Given this list of marker genes Colec10, Fcnb, C1qc, C1ra, Fcna, Igll1, Gzmm, Colec11, Mbl2, Masp1, Cfp, C4b, C1qa, C2, C1s2, Masp2, C1qb, C3, Cfd, here is a description of the gene set: studied in species Mus musculus part of: Complement cascade electronically inferred by orthology from the curated human pathway This event has been computationally inferred from an event that has been demonstrated in another species.<p>The inference is based on the homology mapping from PANTHER. Briefly, reactions for which all involved PhysicalEntities (in input, output and catalyst) have a mapped orthologue/paralogue (for complexes at least 75% of components must have a mapping) are inferred to the other species. Reactome Pathway: Initial triggering of complement